Given this list of marker genes CCDC18, CXADR, HMGB3, HOXD10, SLC35A3, OPA1, PER3, USP25, U2SURP, PRPF39, ZNF367, BAG5, CEP44, RAD51AP1, ODF2L, POLD3, BRIP1 (BRCA1 interacting helicase 1), NSD3, WDR76, REV1, ZNF678, GRAMD1C, SYNJ1, MAP3K21, USP37, MEIS1, PPM1A, MCPH1, ETS2, KCTD3, CEP152, PARD6B, PMAIP1, ATAD2, GAS2L3, ESR1, SKIL, OCLN, SMC4, AHCTF1, GINS1, TCAM1P, NUP210, SF3B1, TOPBP1, SNRPA1, ERMP1, PAXBP1, UPF3B, ZRSR2, HNRNPA1, ARHGAP5, GSPT1, DR1, BHLHE40, GOLGA8A, C18orf54, ATAD2B, CASK, PLSCR4 (NCBI Gene Id 57088), NUF2, CENPI, FAM72C, STS, HOXB3, HELLS, CREBZF, SLF2, CCHCR1, LAMTOR5-AS1, CDCA7, SLF1 (NCBI Gene Id 84250), UBXN7, E2F7, ANKRD36B, E2F8, ENOSF1, KLHL2, RBBP4, UHRF1, PIGA, FAM50A, TUG1, BARD1, NEK2, CDKN2A, INTS7, TMEM30B, RASEF, EP300-AS1, CCDC14, CENPJ, STAG1, MYO5C, PXYLP1, HOXA10, GCH1, SIK1, XIST, WDHD1, CCDC150, NUP62CL, PRKX, THAP9-AS1, LINC00342, NASP, CENPF, MIS18A, LMNB1, DIP2A, ARL13B, CDC42BPA, RMI1, NR1D2, HSPA1A, FAM199X, MCM3, LINC02977, CDK1, PRDM15, PRMT6, CCNL1, FMR1, ZFX, DDX59, EZH2, SYCP2, BRWD1, ZBTB8A, SS18L1, GEN1, ANAPC5, ABCA5, C2CD5, HACE1, XK (NCBI Gene Id 7504), SHOC1, ZNF532, KRT19, DTL (denticleless E3 ubiquitin protein ligase homolog), LNPK, CALML4, RIMKLB, CHML, NDUFB4, POLA1, HOXA9, HNRNPU, CASP8AP2, ANKRD13C, B4GALT4, RFC5, KDM6A, TMPO (thymopoietin), SPICE1, SUDS3, HLTF, KNL1, KNTC1, JPX, FNBP1L, ATP8B1, DDX3X, BCL2L11, MECOM, ZBTB21, PSIP1, PDIK1L, EYA2, PRPS2, OSBPL11, TXNDC16, TMCC1, ANXA2R-OT1, GART, ZNF236, FGFR1OP2, CENPU, CDC7, CDKN2B, DONSON, ZGRF1, MTF2, CCNE2, ELF3, TSIX, PRELID2, SCML1, MSL2, RBL1, NEK4, ANKLE2, CENPK, REL, KIF15, NR4A2, here is a description of the gene set: Human papillomaviruses (HPV) are associated with nearly all cervical cancers, 20% to 30% of head and neck cancers (HNC), and other cancers. Because HNCs also arise in HPV-negative patients, this type of cancer provides unique opportunities to define similarities and differences of HPV-positive versus HPV-negative cancers arising in the same tissue. Here, we describe genome-wide expression profiling of 84 HNCs, cervical cancers, and site-matched normal epithelial samples in which we used laser capture microdissection to enrich samples for tumor-derived versus normal epithelial cells. This analysis revealed that HPV(+) HNCs and cervical cancers differed in their patterns of gene expression yet shared many changes compared with HPV(-) HNCs. Some of these shared changes were predicted, but many others were not. Notably, HPV(+) HNCs and cervical cancers were found to be up-regulated in their expression of a distinct and larger subset of cell cycle genes than that observed in HPV(-) HNC. Moreover, HPV(+) cancers overexpressed testis-specific genes that are normally expressed only in meiotic cells. Many, although not all, of the hallmark differences between HPV(+) HNC and HPV(-) HNC were a direct consequence of HPV and in particular the viral E6 and E7 oncogenes. This included a novel association of HPV oncogenes with testis-specific gene expression. These findings in primary human tumors provide novel biomarkers for early detection of HPV(+) and HPV(-) cancers, and emphasize the potential value of targeting E6 and E7 function, alone or combined with radiation and/or traditional chemotherapy, in the treatment of HPV(+) cancers. Up-regulated genes in head and neck cancer compared to cervical carcinoma samples. species: Homo sapiens from publication Pyeon D, Newton MA, Lambert PF, den Boon JA, Sengupta S, Marsit CJ, Woodworth CD, Connor JP, Haugen TH, Smith EM, Kelsey KT, Turek LP, Ahlquist P (PMID 17510386) Human Gene Set: PYEON_CANCER_HEAD_AND_NECK_VS_CERVICAL_UP